Given this list of marker genes GLI3, STK11, ASCL1, IGF2, CGA, ARHGAP35, EXT1, NOG (noggin), IL6, TSPO, DDR1, TNFAIP3, CELA1, MAPK1, LIMS2, TGFB1, PCSK9, NRG1, ERBB4, MAP2K2, UPB1, ATP7B, RAP1A, BMP4, PYGO2 (pygopus family PHD finger 2), EPHA2, HOXB9, NKX3-1, SOX10, RXFP1, LIPA, BCL11B, TP63, AKT2, COBL, RPGRIP1L, UGT1A7, TBX19, NFIB, NOTCH2, VTN, CAV3, FADD, ISL1, NODAL, ZBTB7B, ESRP2, VDR, PROP1, SMARCC1, IGF2R, CD2AP, DNAAF1, ID4, AKT1, CEACAM1, PSAP, EDN1, PRDX2, NRG3, DBP, SIX4, CEBPG, BAX, CPT1A, GDF7, NTN1, HIPK2, PLXNA1, RARA, CYP7B1, ERRFI1 (ERBB receptor feedback inhibitor 1), SOSTDC1, LSR, FGF7, CDKN1C, ARHGAP5, KDM5B, CYP19A1, HOXB13, EGFR, NKX2-8, PRKCSH, RTN4, MED1, ARF6, GATA2, CUL3, SRSF1, TPH1, IGFBP5, FRZB, WNT11 (Wnt family member 11), ITGA2, FGF10, CDK5RAP3, GPAT4, MYB, ASS1, NOTCH4 (NCBI Gene Id 4855), CRIPTO, COA5, TUBB1, GLI2, ARMC5, NR5A2, BSX, CSN3, NPHP3, BAAT, FGFR1, NFKB1, FOXB1, XBP1, TFCP2L1, ASCL3, INSM1, MMP2, SEC63, EGF, GCM2, CCL11, MAD1L1, PLAG1, TFAP2C, WNT5A, PNPT1, GHRH, ORAI1, JARID2, TNF, PAX8, SFRP1, NF1, DUT, OXTR, WLS, EDAR, ACAT1, SNAI2 (NCBI Gene Id 6591), GFER, NKX2-3, NR0B1, TCF21, PML, HOXD9, RREB1 (NCBI Gene Id 6239), AIRE, ACER1, SERPINB5, SP3, NR5A1, POU1F1, CSNK2A2, TYR, CEBPB, FOXN1, BRAF, NKX2-1, PLXND1, CAPN1, PRL, LAMA5, LEF1, ALOX15B (NCBI Gene Id 247), LHX3, STAT5B, ARID5B (NCBI Gene Id 84159), ATM, TGFB2, THRA, RAF1, WDR77, DAG1, KRAS, FGF8, CCKBR, HOXB3, SOD1, PHF2, IRS2, LBH, IGSF3, FOXF1, MT-CO2, INHBB, MAN2A1, HOXD13, CCDC39, RAG1, SRC, CCDC40, HK2, BRCA2, ATP2C2, NR3C1, NPC1, ADA, PITX1, OAS2, BMP2, RBPJ, EDNRA, CPS1, FA2H, IGF1, GLI1, PTN, LAMA1, SRF, CRIP1, UGT1A10, ZNF703, SCRIB, HPN, GATA6, TGFB3, LRP5, GHRHR, TGFBR3, SLC46A2, RIPK3, WT1, DEAF1, HOXA9, INSR, TBX3, FGL1, CDO1, TGFBR2, PDX1, TBX1, GATA3, FOXH1, ROBO1, EPHB3, IHH, WNT3A, PRLR, HES1, CSN2, SLC29A1, TBX2, CSF1R, WNT3, NCOR2, HNF1B, CTNNB1, TG, SLC6A3, ONECUT1, RARG, OTC, TNC, UGT1A8, TNFRSF11A, HAND2, E2F7, APOA1, PDGFA, LMO4, HMGCS2, HMGA2, SIX3, NHERF1, ABCB1, VEGFA, PKD1, SOD2, PROX1, STAT6, CSMD1, FASN, PPDPF, PCNA, FGF2, FOXE1, NOTCH1, DKK3, MAP2K1, HESX1, XDH, RAP1GAP, PERP, SHH, HGF, PKD2, WNT1, MESP1, PITX2, SRP54, BCL2, ASH1L, CRHR1, FKBP4, RPS6KA1, MSN, PTCH1, SOX3, UPRT, TAF10, SOCS2, ZDHHC21, WNT2, NCOA1, AREG, UPF2, HIF1A, HLX, SRD5A1, AURKA, CDKN1B, BTBD7, PDGFRA, SIX1, IQGAP3, ZIC3, HOXA11, POU3F2, BMPR1A, JAK2, JUN, WNT10A, TGM2, PHB2, PCK2, HOXA13, SMAD3, CCNB2, USF2, ALDH1A3, NRP1, APLN (NCBI Gene Id 8862), UBE3A, ELF5, MTCO2P12, PSEN1, RCBTB2, TGFBR1, AR, NME1, CREB1, ETV5, CRH, CDKN2A, NEURL1, MSX2, FOXI3, ZMPSTE24, ESR1, PAX6, BCL2L11, CYP1A1, SERPINF1, SERPINE2, SMAD4, FEM1B, HOXA5, ID2, HOXA10, OTP, EZH2, RHBDD3, MDK, STRA6, CLCN2, HOXD3, GUCD1, PIK3CA, NAGLU, ZBTB1, FLT3, ELK1 (ETS transcription factor ELK1), TGFA, CSF1 (colony stimulating factor 1), MET, SMARCB1, GSX1, RPS15, LATS1, CAD, WNT4, EZR, ALDH1A2, PSAPL1, HOXA3, UGT1A9, ATF2, SOX2, BTRC, PBX1, FOXC1, POLB, E2F8, PTCD2, EDA, SRSF5, CRKL, CFLAR, ELF3, NKX2-5 (NK2 homeobox 5), TWSG1, PTF1A, IL10, CAV1, FGFR2, IRF6, CACNB4, MSX1, RB1CC1, CTC1, ASXL1, FRS2, FBXW7, HSPA12A, CITED2, ABL1, MPST, WNT7B, MAFB, STAT5A, CEBPA, RELA, FOXA1 (forkhead box A1), BMP7, SEMA3C, SLC7A5, EAF2, SMO, TNFSF11, MTX1, KRT76, CLDN1, GPX1, PCK1, CCND1, ONECUT2, PRMT5, HNF1A, ACADM, MAPK3, CDH1, SULF1, UCP2, PGR, SALL1, NTN4, SOX9, DRD2, HNRNPD, SULF2, here is a description of the gene set: The process whose specific outcome is the progression of a gland over time, from its formation to the mature structure. A gland is an organ specialised for secretion. species: Homo sapiens Human Gene Set: GOBP_GLAND_DEVELOPMENT